The following is a description of a gene set: IFNs are highly pleiotropic cytokines also endowed with marked anti-angiogenic activity. In this study, the mRNA expression profiles of endothelial cells (EC) exposed in vitro to IFN-alpha, IFN-beta, or IFN-gamma were determined. We found that in HUVEC as well as in other EC types genes were upregulated (>2-fold increase) by IFNs, including genes involved in the host response to RNA viruses, inflammation, and apoptosis. Interestingly, genes showed a >5-fold higher induction by IFN-alpha in EC compared to human fibroblasts; among them, the gene encoding the angiostatic chemokine CXCL11 was selectively induced by IFN-alpha in EC along with other genes associated with angiogenesis regulation, including CXCL10, TRAIL, and guanylate binding protein 1 (GBP-1). These transcriptional changes were confirmed and extended by quantitative PCR analysis and ELISA; whereas IFN-alpha and IFN-beta exerted virtually identical effects on transcriptome modulation, a differential gene regulation by type I and type II IFN emerged, especially as far as quantitative aspects were concerned. In vivo, IFN-alpha-producing tumors over-expressed murine CXCL10-11, GBP-1 and TRAIL, with evidence of CXCL11 production by tumor-associated EC. Overall, these findings improve our understanding of the anti-angiogenic effects of IFNs by showing that these cytokines trigger an anti-angiogenic transcriptional program in EC. Moreover, we suggest that quantitative differences in the magnitude of the transcriptional activation of IFNresponsive genes could form the basis for cell-specific transcriptional signatures. Human Gene Set: GSE3920_IFNA_VS_IFNB_TREATED_ENDOTHELIAL_CELL_UP studied in species Homo sapiens from publication Indraccolo S, Pfeffer U, Minuzzo S, Esposito G, Roni V, Mandruzzato S, Ferrari N, Anfosso L, Dell'Eva R, Noonan DM, Chieco-Bianchi L, Albini A, Amadori A (PMID 17202376) Genes up-regulated in endothelial cells: interferon alpha versus interferon beta., and this is the list of marker genes: AVPI1, PLEKHF1, ECM1, RAB3IP, CUX1, VAX2, ST3GAL2, OTULINL (NCBI Gene Id 54491), IL23R, GGT5, SYNPO2, RCBTB2, IL1R1, DARS2, LPP, NDUFS3, DGAT1, SESTD1, RAB4A, HP1BP3, NAGK, PNPLA7, PARP6, CRMP1, AMER1, MYO10, ARHGAP31, MACF1, IGFBP4, CD163L1, IFITM1, NT5E, HGSNAT, KLHL6, QPRT, SLC41A2, BCAS3, PSD3, JAKMIP1, RARG, DAB2, CPNE3, WDTC1, PAQR7, NEBL, KCNH5, ACSBG1 (acyl-CoA synthetase bubblegum family member 1), NPAS2, RAB6B, PLAUR, SH3BGRL2, ZNRF3, BTG1, FAU, SLC26A11, CCDC63, HNRNPH3, NIN, CNN3, ITGA3, HPS3, ABCA5, INHA (inhibin subunit alpha), ADPRH, LYSMD2, ABTB1, MMP9, PLEKHB1, ARMCX2, DPP4, ST6GALNAC3, ERICH1, RHEBL1, MARCHF3, ELOVL6, NCALD, RGS10, TMEM176A, MEIS3, LTB, TXK, IL17F, CLEC12A, UPP1, SLC49A4, ST6GALNAC1, SYNE2, NXPE3, RASA3, ACOT11, GNA15, CD72, LARGE1, CD24, OSTF1, KIT, RORA, ABLIM2, TRPM6, BMAL1, RAPGEF4, UROD, PRKCB, PRKACB, TMEM50A, FAH, TGM2, TARS2, FCGR2B, EXOC6B (NCBI Gene Id 23233), DDR1, ATP8A2, TDRKH, CPA3, RIPK3, ADD3, DGKG, IL17RE, RAMP1 (NCBI Gene Id 10267), EIF4E3, ADGRG5, FAM124B, SBF2, CYSLTR2, ACVR1B, APPL2, FHIP1B, SOCS1, AMACR, IKBKE, INF2, LRRC1, NR1D2, RND3, ATP6V1B1, SDC4, IL6R, B3GNT5, ABHD15, ANO10, TRAT1, GPR146, NEB, RALGPS2, KLHDC1 (kelch domain containing 1), DISP1, IGF1R, KAT2B, FBXO7, PNMA1, CPM, GNB4, HSPBAP1 (NCBI Gene Id 79663), TMEM176B, TTBK1, SERPINI1, TMEM255B, IFNGR2, CYP2S1, DPY19L3, ZBTB20, ITGA7, GMFG, PDE6D, HOOK2, AQP3, IMMP1L, EMB (NCBI Gene Id 133418), ASCC3